The following is a description of a gene set: Human Gene Set: MORF_CCNI Neighborhood of CCNI Neighborhood of CCNI cyclin I in the MORF expression compendium studied in species Homo sapiens, and this is the list of marker genes: MRPL9, ATF4, DDX49, EIF3E, HNRNPD, RAB8A, FAM168B, SRSF2, GNB2, NONO, SUMO2, ANP32B, BTF3, ERP29, HNRNPK, RSL1D1, EIF4B, EEF1G, YWHAZ (tyrosine 3-monooxygenase/tryptophan 5-monooxygenase activation protein zeta), BRD2, GABARAP, RHOA, ARPC3, SRRM1, SLC25A3, HINT1, EIF3F, RPS6, RPLP2, PCBP2, HDAC1, PTP4A2, ATP5F1A, RPL14, RPL21, RPS27A, HDGF, GNB1, RPL22, UCP2, SRP14, DDOST, KHDRBS1, RPL10A, RPS12, EIF4G2, NACA, RPL30, HNRNPA1 (NCBI Gene Id 780920), DAZAP2, ANAPC5, RO60, SRSF9, PRPF8, CBX3, ACP1, LSM14A, MACROH2A1, YBX1, GNAS, EIF4A2, FAU, USP22 (ubiquitin specific peptidase 22), RPL24, EEF2, RPL5, HNRNPC, CHD4, RNPS1, RACK1, U2AF1, SF3A1, EIF3D, JTB, TAX1BP1, EIF3H, TMEM123, DPF2, NPM1, RPL7, HNRNPUL1, CCNI, BAZ2A, WDR1, RPL18, EIF4A1, SNX3, NAP1L1